Given this list of marker genes TOM1, IL2RG, LCK, CD40, BTK, BACH2, CD40LG, TCF3, here is a description of the gene set: species: Homo sapiens An abnormally decreased level of immunoglobulin E (IgE) in blood. Decreased circulating IgE concentration Human Gene Set: HP_DECREASED_CIRCULATING_IGE_CONCENTRATION